The following is a description of a gene set: species: Mus musculus Genes selectively expressed by quiescent (non-proliferating) cells and promote quiescence in embryonic day 14.5 mouse cortex. from publication Bedogni F, Hevner RF (PMID 34321999) Mouse Gene Set: HEVNER_CORTEX_QUIESCENCE, and this is the list of marker genes: Ccng2, Ecrg4, Thrsp, Cdkn2a, Cdkn1c, Cdkn1a, Gas7, Aldoc, Ppp2r1b, Cdkn1b, Cirbp, Btg1, Btg2